Given this list of marker genes Wnt10b (NCBI Gene Id 22410), Six1, Intu, Hand2, Hdac2, Nkx2-5 (NCBI Gene Id 18091), Six4, Kit, Lef1, Bnc2, Sox2, Prdm16, Wnt10a (wingless-type MMTV integration site family, member 10A), Cyp26b1, Hoxc13, Krt13, Shh, Tbx1, Wdpcp, Bdnf, Ntf5, Egfr, Gli3, Hdac1, Fuz, Ctnnb1, Nkx2-6, here is a description of the gene set: The process whose specific outcome is the progression of the tongue over time, from its formation to the mature structure. The tongue is the movable, muscular organ on the floor of the mouth of most vertebrates, in many other mammals is the principal organ of taste, aids in the prehension of food, in swallowing, and in modifying the voice as in speech. species: Mus musculus Mouse Gene Set: GOBP_TONGUE_DEVELOPMENT